The following is a description of a gene set: Visual fixation instability species: Homo sapiens A deficit in the ability to fixate eye movements in order to stabilize images on the retina Human Gene Set: HP_VISUAL_FIXATION_INSTABILITY, and this is the list of marker genes: CCDC88A, ASAH1, ITPR1, CLP1, RNF13, PET100, ASPA, VPS4A, TEFM, CLCN3, AMPD2, SLC39A8, ANKH, MAB21L1